Given this list of marker genes PDE7B, BCOR, REC8, CFAP36, ADAM19, WDR86, LIF, UBQLN4, SCART1, RNF144A, AHR, IFNGR2, GAB2, IL2RA, IRS2, DPP4, KIT, ALAS1, HPGD, TTN, CD84, SLAMF1, BCL3, NTRK1, ACOX1, GRINA, PKIB, STAP1, ARHGAP5, INPP4B, TNFSF14, SVOPL, RHOBTB3, COL9A2, STARD4, KRT1, ANTXR2 (NCBI Gene Id 118429), ANXA5, CCNG2, CHDH, MMP25, SAMSN1, GNA15 (G protein subunit alpha 15), MBOAT7, LINC02694, CYSLTR1, BACE2, DOK4, SOCS3, PDLIM5, IL17RB, MEG3, PTGDR2, TSPAN2 (NCBI Gene Id 10100), CFH, MGAT5, KLF5, CD200R1, PHLDA1, CCDC86, IL13, CTSZ, JUP (junction plakoglobin), RASGRP4, NDFIP2, RENBP, CSGALNACT1, BATF, SWAP70, CD82, GATA3-AS1, CMPK2, ZNF667-AS1, SEPTIN11, S100P, PTGER2, ECRG4, SOCS2, PTPRN2, CHCHD10, MGLL, ROGDI, DAPK1, CAMK1, LGALS12, LSR, SCN2A, GADD45G, NAMPT, GFI1, RGS18, EGLN3, SOS1, GDPD5, GRK5 (G protein-coupled receptor kinase 5), TNFSF10 (NCBI Gene Id 8743), MBOAT2, CAPG, SPINT2, BCAR3, MAST4, IL9R, PHTF2, TMEM220, CENPV, DENND6B, ARL4A, HSD17B4 (hydroxysteroid 17-beta dehydrogenase 4), FSTL4, MSI2, EPAS1, CCR2, RNF130 (NCBI Gene Id 55819), TNFRSF18, PKP2, IRF2BPL, PRNP, NR4A3, MDFIC, ACSL4, TIMP1, CACNB3, ASPH, GAP43, EPS8L2, LPCAT2, MAF, IL1RL1, C1orf162, SH2B3, BIRC3, TIAM1, TSPO, DUSP10, CMTM8, TYMP, ZG16B, TMEM273, PPARG, PSTPIP2, TNFSF11, THEM4, PLAGL1, ATP1B1, THG1L, KIF3A, DUSP6, SEL1L3, RAD50, HPGDS, here is a description of the gene set: from publication He P, Lim K, Sun D, Pett JP, Jeng Q, Polanski K, Dong Z, Bolt L, Richardson L, Mamanova L, Dabrowska M, Wilbrey-Clark A, Madissoon E, Tuong ZK, Dann E, Suo C, Goh I, Yoshida M, Nikolić MZ, Janes SM, He X, Barker RA, Teichmann SA, Marioni JC, Meyer KB, Rawlins EL (PMID 36493756) species: Homo sapiens Human Gene Set: HE_LIM_SUN_FETAL_LUNG_C4_ILC2_CELL ILC2